The following is a description of a gene set: Genes basally silent, with hypermethylated promoters, up-regulated by the combination of TSA and decitabine in RKO cells (colorectal cancer). from publication Suzuki H, Gabrielson E, Chen W, Anbazhagan R, van Engeland M, Weijenberg MP, Herman JG, Baylin SB (PMID 11992124) Aberrant hypermethylation of gene promoters is a major mechanism associated with inactivation of tumor-suppressor genes in cancer. We previously showed this transcriptional silencing to be mediated by both methylation and histone deacetylase activity, with methylation being dominant. Here, we have used cDNA microarray analysis to screen for genes that are epigenetically silenced in human colorectal cancer. By screening over genes, we show that our approach can identify a substantial number of genes with promoter hypermethylation in a given cancer; these are distinct from genes with unmethylated promoters, for which increased expression is produced by histone deacetylase inhibition alone. Many of the hypermethylated genes we identified have high potential for roles in tumorigenesis by virtue of their predicted function and chromosome position. We also identified a group of genes that are preferentially hypermethylated in colorectal cancer and gastric cancer. One of these genes, SFRP1, belongs to a gene family; we show that hypermethylation of four genes in this family occurs very frequently in colorectal cancer, providing for (i) a unique potential mechanism for loss of tumor-suppressor gene function and (ii) construction of a molecular marker panel that could detect virtually all colorectal cancer. studied in species Homo sapiens Human Gene Set: SUZUKI_RESPONSE_TO_TSA_AND_DECITABINE_1A, and this is the list of marker genes: SFRP1, PYROXD2, RTL8C, FOLH1, ANGPT2, KYNU, S100A10, TIMP2, LAMA3, DNASE1L3, COL6A3, SEZ6L, XCL1, CYP4B1, PCDH8, PTGS2, CDKN2A (cyclin dependent kinase inhibitor 2A), LAMA2, ADGRL2, TIMP3, SNRPN